Given this list of marker genes PRPF3, BBS1, RDH12, OCRL, RPGRIP1L, AIPL1, DYNC2I1, LPL, MT-TN, GNA11, PEX10, OFD1, CLCN3, SLC24A5, NDUFA1, SDHAF1, VPS37D, UBA5, FBLN5, SLC35A2, ERCC1, NEU1, CHEK2, LRIT3, CLN3, TPP1, RAB28, DAG1, AP3B2, ENG, ODAD3, TTC8, POGZ, FGF12, TMEM237, GABBR2, NPHP4, CLDN19, CHRDL1, C9, CABP4, ZEB2, FOXJ1, BAZ1B, ERCC6, GABRB2, STAT3, KCNJ13, HLA-DRB1, AGBL5, RP9, PGK1, DARS1, RPS6KA3, CTLA4, LOXL3, POLG, IRF5, XYLT2, ZNF469, TERC, IFNG, KLHL7, ATP1A3, ALG6, ELMO2, TEAD1, SIX3, DNAH5, TTLL5, KIZ, ZFYVE26, ARHGEF18, CLTC, CFAP298, ASPA, POMGNT2, PRPF8, UBAC2, PAX6, TMEM127, EFEMP1, PLOD1, CRYAB, ARL6IP6, SCAPER, TUBGCP6, IFT80, SZT2, TELO2, WRN, NME5, RAX2, FDXR, MAPKAPK3, MFRP, DNAI1, PDE6G, B3GLCT, RXYLT1, CTSA, ALG8, C4A, ZFX (zinc finger protein X-linked), MT-ND6 (NCBI Gene Id 4541), CEP164, LRRC56, LRRC32, BBS7, TNIP1, SDHB, SYNGAP1, PAK2, CEP83, FOXE3, PNPLA6, NGLY1, ATP6V0A2, TERT, CA4, ERCC5, WDR19, RPL10, RB1, ERAP1, PRPH2, CTNNB1, SOX2, RIMS2, ATXN7, MT-CO2, TXNDC15, DNAAF1, CHD7, ESS2, SIM1, SDHA, ADAMTSL4, CAV1, STUB1, COL9A2 (collagen type IX alpha 2 chain), DNAAF2, KCNB1, TMEM67, ARMC9, IL12A-AS1, IDH3B, CYP4V2, TNFSF4, ATXN2, DGCR8, HSD17B10, NDUFAF1, EBP, HADH, VWA8, USH1G, TENM3, NHS, MKS1, MT-TK, ACD, ROM1, SHH, TBC1D20, HARS1 (histidyl-tRNA synthetase 1), MECP2 (methyl-CpG binding protein 2), NF2, DCT, PRDX1, HSD11B2, STN1, RSPH3, FKRP, CCDC28B, FGFR1, BANK1, MCIDAS, AHR, ESAM, AARS1, PANK2, PGAP1, FAS, XRCC4, RAB3GAP1, PEX13, NEK1, HMCN1, PCYT1A, SYNJ1, RLBP1, SLC6A6, SLC25A15, KATNB1, TRIP13, LOXL1, MT-TH, SEC24C, IVNS1ABP, HADHA, PAX4, SRD5A3, HTRA1, TMEM98, KLRC4, C2CD3, CFAP221, CDH23, HBG1, PIEZO2, ALDH3A2, PDCD1, RAB3GAP2, SELENOI, CTNS, INVS, ADAM9, MAB21L1, SLC25A11, PORCN (porcupine O-acyltransferase), PRDM5, COL11A2, HYDIN, MAK (male germ cell associated kinase), VPS33A, PRDM10, MT-ATP6, DNASE1, COA8, COL4A1, FSCN2, MORC2, DHX38, COX15, ATF6, CEP78, CC2D2A (coiled-coil and C2 domain containing 2A), KIAA0753 (KIAA0753), PTPN22, IDS, OPN1LW, DNAH1, NSD2, MYO6, HCCS, JMJD1C, RPE65, MRPL39 (NCBI Gene Id 64977), STAT4, POMT1, SBDS, KIF3B, EYS, SALL2, INTS11, SAR1B, KIAA0586, ARL3 (NCBI Gene Id 403), ADA2, CYFIP2, ANK1, CASK, PDE6D, FBLN1, ZNF423, TLR4, CACNA1B, KIAA1549, ABCC8, IQCB1, PARS2, SETD2, CFHR1, OPN1SW, EIF4H, CFH, EPAS1, ZPR1, MT-TF, ETS1, CTNNA1, KDM6A, LCK, SUMF1, VPS35L, MEG3, VPS4A, TRNT1, MTSS2, DGCR6, CHN1, SLC13A5, CIB2, DNAAF5, DGCR2 (NCBI Gene Id 9993), FZR1, HMGB3, ABHD12, FOXC1, PCARE (photoreceptor cilium actin regulator), BCOR, RDH11, GALNT3, SF3B1, YWHAG, IFT27, TRIM32, SCN1A, ATCAY, DBR1, ANTXR1, CFAP300, MVK, STK36, FZD4 (NCBI Gene Id 8322), NEK2, TINF2, GTF2IRD2, GAS2L2, YME1L1, TRAF3IP1, SEMA3E, ASXL1, CLEC3B, GDF6, ZNF668, WHRN, SPAG1, COX7B, IGHG1, NCAPG2, IL10, SLC38A8, FCGR3B, JAG1, PEX14, TNFAIP3, KCNA2, PAX2, DNAH9, CLCC1, RMRP, PRUNE1, PUS1, DNM1, GATA3, PRPS1 (NCBI Gene Id 8254), AHDC1, RFC2, SPATA7, RAI1, TSC1, C12orf57, CCM2, GDF3, WARS2, GZF1, BLK, ARV1, COL8A2, LAMA1, AKT1, TRPM3, IDUA, IL12B (interleukin 12B), DYNC2H1, ANO10, DNAJC21, NEK8, PCDH15, CNNM4, UBE3B, STX1A, ALMS1, PLA2G5, DNAAF6, KIF1B, TCTN1, POC1B, IPO8, CTSD, CEP290, GNB5, GUCA1B, DHDDS, GUCA1A, BBS4, ACTA2, MT-TV, MC1R, BBS5, ATP6V1E1, GPIHBP1, SH3BP2, RCBTB1, ODAD1, ACOX1, SURF1, TMEM107, DPM1, CACNA2D4, ATOH7, HGSNAT, DNAAF3, CEP19, TMEM270, GTF2IRD1, CREBBP, LIG3, BBS10, IFT172, CLRN1, CP, PEX19, ISCA1, BBS12, MAN2C1, REEP6, HMX1, PLK4, NUS1, HID1, PTCH1, KIAA0319L, PDE6B, BLM, WFS1, SDCCAG8, IFT140, HPS4, FAM161A, MED12, EDNRB, PEX7, ZMYND10, TRPM1, RERE (arginine-glutamic acid dipeptide repeats), CST3, NDE1, ABCA4, EXOSC2, CSPP1, WWOX, SAMD7, SPTBN1, MFSD8, FAM111A, MPLKIP, SSBP1, LRP2, APOB, DYNC2LI1, B9D1, TCTN3, LZTFL1 (leucine zipper transcription factor like 1), SACS, GTF2H5, NDP, ALG12, IL23R, GPR179, CFI, MT-ATP8, SERPINC1, COL11A1, CNGB1, SIX6, TARS1, SLC45A2, CHM, PDCD10, SDHAF2, NOD2, RAP1B, TUBB4B, SLC37A4, DRAM2, ERCC4, CYP27A1, AIRE, CCR1, CEP41, MAPRE2, ARL2, PEPD, DNAL1, NEK10, KLF11, PEX2, TMEM138, MLXIPL, APPL1, BBIP1, B3GALNT2, OPN1MW, APC (APC regulator of WNT signaling pathway), DNM2, HCN1, DPAGT1, NBN, MPDZ, FLNB (filamin B), HACE1, TYR, VSX1, MCOLN1 (NCBI Gene Id 57192), RTTN, RTL1, POMGNT1, HIRA, NSMCE2, TBX1, AP5Z1, CRLS1, MT-ND2, SALL4, RSPH4A, TNFRSF11B, LAMB2, CCND1, HLA-B, NCF1, BLOC1S3, CDKN2A, MMACHC, DYRK1A, MYD88, NF1, HBG2, ARVCF, CDK19, COMT, TCTN2, ALDH1A3, PMM2, INS, APOE, RRM2B, TOPORS, CACNA2D1, FBXO28, TP53 (tumor protein p53), MGMT, CDH3, PEX12, CPLANE1, MSRB3 (NCBI Gene Id 253827), PDX1, CENPF, TLR7, TMEM218, GPR143, G6PC1, GRK1, CEL, PRPF4, CCDC22, MERTK, MAF, DDR2, IFNGR1, TUB, VHL (NCBI Gene Id 8056), RNU4ATAC, HNF4A, ACVRL1, GCK, VPS13B, YARS1, HEXA, RNF113A, BBS9, RPGRIP1 (NCBI Gene Id 57096), MTTP, OAT, NAA10, PDE6A, ATP5F1A (ATP synthase F1 subunit alpha), NDUFB11, PHYH, HKDC1, DST, PDE6H, ZNF513, SALL1, CLN5, MT-ND1, LRAT, KCNJ11, MITF, HPS6, HEXB, C4B, RP1, PEX3, WASHC5, GUCY2D, GCDH, ETHE1, IFT43, GLB1 (NCBI Gene Id 2720), GNAQ, SDHD, GRIN2D, TREX1, ELN, PEX16, COG1, CYSLTR2, NR2E3, PRPF6, DNAAF11, MT-TW, GABRA5, EDN3, P3H2, MSTO1, TBX22, GNB3, CBS, LPAR6, HLA-DPB1, LYST, EPG5, PACS2, TIMP3, IFT52, RGR, IGFBP7, CFHR3, DLAT, SLC19A2, PCNA, EEF1A2, ADAR, POMT2, DHX16, CDK4, ACTB, FH, PIBF1, PDZD7, DACT1, SLC1A2, B9D2, GMPPB, TAF2 (TATA-box binding protein associated factor 2), CACNA1A, ITPR1, FLII, INTS1, IFT88, RSPH9, CLN6, MT-CO1, ARL13B, OTX2, FUCA1, MAGEL2, TRAPPC9, ATP6V1A, ZEB1, IQSEC2, MAN2B1, GABRG2, MICOS13, ACTG1 (NCBI Gene Id 71), NLRP3, YAP1, FZD5, INSR, PXK, TSC2, RAX, MAFB, IL12A, MT-TS2, DNAH11 (dynein axonemal heavy chain 11), MECR, MYOC, FCGR2B, PPP2R3C, UNC119, CCNQ, RNASEH1, RD3, MT-CYB, HBB, DEAF1, CRPPA, SCN8A, KRT71, COL9A1, NEUROD1, TNFRSF11A, MLX, SCN3A, ASAH1, DNAAF4, GP1BB, GNAT1, TRAK1, IMPDH1, DNMT3B, NPHP1, CEP120, CRX, CDKN2B, ATP5F1D, PIGA, RDH5, LIPH, PIGL, NPHP3, FLCN, NTRK2, FLVCR1, KCNV2, RSPH1, RIMS1, ARSG, CWC27, DNAJB13 (DnaJ heat shock protein family (Hsp40) member B13), SAG, POT1, GDF2, SMAD4, DRC1, MT-ND3, OVOL2, WT1, ATP5F1E, TTPA, PIK3CA, CERKL, ADAMTS18, CPLX1, MT-TL1, SNRNP200, TUBB, PROM1, TMEM231, MIA3, DALRD3, VCAN, CNGA3, CHST6, POU3F4, GABRA2, PDGFRB, DNAJC30, NECAP1 (NECAP endocytosis associated 1), CELF2, DNAI2, METTL27, CCNO, IMPG1, ALDH6A1, DYNC2I2, PRF1, PRCD, ACBD5, MIR204 (microRNA 204), FIBP, HK1, CLCNKB, ERCC3, HLA-A, GRN, BEST1, CCDC40, AP3D1, RNU7-1, NME8, TLCD3B, POMK, CNGA1, BCL11A, RBP3, B4GAT1, CA2 (carbonic anhydrase 2), CAPN5, PROS1, KCNC2, CDHR1, SCLT1, RBP4, XYLT1, ESPN, ATP2B2, PEX26, SDHC, ODAD2, EXOSC3, DSE, GTF2I, OCA2, LMNA, CTBP1, LARGE1, MT-ND4, RS1 (NCBI Gene Id 6247), MT-ND4L, THSD1, HHAT, GSS, AHI1, GALC, IDH3A, HADHB, SLC38A3, P4HA2, DLST, SPEF2, TWNK, TMEM216 (NCBI Gene Id 51259), PISD, FKBP6, ODAD4, USP45, USH2A, KLF1, MKKS, COL9A3, PEX6, ELOVL4, ITGAM (NCBI Gene Id 3684), MDH2, FBN1, DPYSL5, COL18A1, PUF60, GGCX, CCDC39, ATPAF2, RNF216, PSAP, NOTCH2NLC, POLR3A, COQ2, MT-CO3, TMCO1, CACNA1F, TSPAN12, PRPF31, SMPD1, RAB18, LETM1, MYO7A, ARL6, ENPP1, HLA-DPA1, NDUFA9, ATG7, MPV17, GNAT2, SOX10, GM2A, KRAS, TRAPPC2, ITM2B (NCBI Gene Id 9445), PPP3CA, TK2, PIGG, DPYD, LCA5, GRHL2, FOXG1, SMCHD1, GTF2E2, FBN2, SEMA4A, CHST14 (carbohydrate sulfotransferase 14), CLIP2, KRT25, MEFV, FGF3, PEX11B, CTC1, AGXT, DNMT3A, ZNF408, KIF11, ARL2BP, F12, IFT74, MYO5A, CNGB3, GBA1, UFD1, NMNAT1, IMPG2, SLC25A19, KIF5A, PEX1, IKBKG (inhibitor of nuclear factor kappa B kinase regulatory subunit gamma), LRP5, PPT1, MT-TQ, CFAP418, FRG1, TERF2IP, HNF1A (NCBI Gene Id 6927), WDPCP, ATP5MK, MAX, USH1C, NYX, ERCC2, NELFA, AMACR, TRIM44, TUBGCP4 (tubulin gamma complex component 4), RPGR, ADGRV1, RHO, TFAP2A, COX8A, ZMYM3, SPP1, RREB1, JAZF1, DUX4L1, RELN, TBL2, INPP5E, IRAK1, GNPTAB, TULP1, BCS1L, NRCAM, DUX4, COL2A1, CNKSR2, RP1L1, PRSS56, SLC7A14, CFAP74, ACO2, ABCB6, DPP6, NRL, MT-ND5 (mitochondrially encoded NADH:ubiquinone oxidoreductase core subunit 5), KMT2D, APOC2, SLC12A6, BBS2, C1QTNF5, SYCE1, CR2, SLC24A1, BUD23, UBE2L3, ACTL6B, KRIT1, TRIM37, UGP2, SPG11, CLCN2, VPS41, PTEN, PRTN3, ALPK1, CRB1, WAC, GFPT1, CFAP410, CARS1 (cysteinyl-tRNA synthetase 1), BMP4, IFT122, BAP1, ATP1A2, SH2B1, ABCC6, GRM6 (glutamate metabotropic receptor 6), OPA1, PITPNM3, RET, PEX5, PRR12, HPS5, FKTN, BLOC1S5, CYP1B1, HSPD1, DLK1, FGFR2, PDE6C, RP2, TTC21B, ERCC8, NDUFS2, KRT74, LIMK1, TTC12, ADAMTSL1, TXN2, here is a description of the gene set: A structural abnormality of the retina. Human Gene Set: HP_ABNORMAL_RETINAL_MORPHOLOGY Abnormal retinal morphology species: Homo sapiens